Given this list of marker genes EPHB6, CEACAM7, BBLN, SERPINF1, MT1X, SPICE1, BDH1, NME3, MID2, PIM1, MRC1, MAP3K3, DDX11, HERC2P3, PROZ, KCNS3 (potassium voltage-gated channel modifier subfamily S member 3), DGCR2, LRCH1, CBL, ZNF510, ZC3H7B, HOXD8, EN2, SCN7A, GCA, MICA, SYNE1, VWA5A, ERC1, CA11, CXCR2 (NCBI Gene Id 3579), NEURL1 (NCBI Gene Id 9148), KAT2A, MVD, KRT34, MVP, GATAD1, ZKSCAN5, H2BC10, ARHGEF11, LMO7, IRF9, PPP2R5D, RAPSN, TBXA2R, CDC25B, GYPB, SEC14L2, CXCR6, GIPC1, HPGD, SRCAP, RGP1, EYA2, RAB31, KDELR3, PIM2, TNFAIP3, HSF2BP, TYRP1, PHLDA2, DGKA, ID2, FYB1, SLCO2B1, DCBLD2, SLC46A3, H2AC17, FOXO4, ITGB8, SOX4, DISC1, PENK (proenkephalin), FNTB, MAPK11, SIRPA, IRF3, ACIN1, PLA2G4C, HMGN2, IQCE, SLC25A14, RBM38, RPL14, HDGF, RBL2, PARVB, MYOC, RFNG, CTSK, BLM, TXNIP, TRAFD1 (TRAF-type zinc finger domain containing 1), THEMIS2, C2CD2, WWOX, ITGB2, SIK1, P2RX5, TRIM66, MFNG, DGKB, NAAA, MAPK3, SC5D, GABBR1, PPIF, PRKD1, PIK3IP1, RGS1, TIMM17B, ARHGEF18, SRD5A1, RPS14, TPM1, SOCS1, CADPS, XDH, CTSA, FGFR1, FAM161A, TOB1, FLRT1, AUH, PAPSS2, TBC1D9, TREX1, H4C3 (H4 clustered histone 3), TRIO, ID1, SETD1B, SERPINB5, MPZL1, SOX5, TRAF3IP2, ZNF507, PCDH7, B3GALT4, TRIB2, NUCB1, TPM2, GPI, IMPDH1, CXCR4, SHOX, OMD, SIGLEC6, DNASE1L1, RPS17, CENPE, HMGN3, RDH5, CLDN9, CXCL12, PEMT, KLF5, APOB, PIP4K2B, NUP210, ST3GAL1, PPEF2, CASP4, SUN2, CCRL2, FAM3A, GUCY2D, ZNF101, GLRA3, USP19, ACAP1, LRIG1, PLA2G1B, BCKDHA, PHKG2, COL14A1, HMGB2, PNPLA6 (patatin like phospholipase domain containing 6), CASQ2, PIEZO1, TSC22D4, TAFAZZIN, DDIT3, H1-4, ACAA1, TMSB10, SPP2, MED24, ADA (adenosine deaminase), CIZ1, CRYGD, DNAJB1, FCHO1, HCRTR1, CDK19, FHIT, CD302 (CD302 molecule), TANC2, PER1 (period circadian regulator 1), MINDY2, here is a description of the gene set: Gene expression profile of LysMCre/Cre and KLF2∆/∆ primary peritoneal macrophages following 6 hours of LPS treatment. We used microarrays to detail the global program of gene expression following LPS stimulation of LysMCre/Cre and KLF2∆/∆ primary peritoneal macrophages. We identified distinct classes of genes that were altered following LPS stimulation. studied in species Homo sapiens from publication Mahabeleshwar GH, Kawanami D, Sharma N, Takami Y, Zhou G, Shi H, Nayak L, Jeyaraj D, Grealy R, White M, McManus R, Ryan T, Leahy P, Lin Z, Haldar SM, Atkins GB, Wong HR, Lingrel JB, Jain MK (PMID 21565532) Genes up-regulated in peritoneal macrophages treated with LPS: wildtype versus KLF2 knockout. Human Gene Set: GSE26727_WT_VS_KLF2_KO_LPS_STIM_MACROPHAGE_UP